Given this list of marker genes PDGFRA, here is a description of the gene set: species: Homo sapiens Reactome Pathway: PDGFR mutants bind TKIs Aberrant signaling by activated forms of PDGFR can be inhibited by tyrosine kinase inhibitors (TKIs). PDGF receptors are class III receptor tyrosine kinase receptors, also known as dual-switch. Dual-switch receptors are activated through a series of phosphorylation and conformational changes that move the receptor from the inactive form to the fully activated form. Type II TKIs bind to the inactive form of the receptor at a site adjacent to the ATP-binding cleft, while type I TKIs bind to the active form.<br><br>Primary mutations in PDGRFA occur in the activation loop, with a minor fraction found in the juxtamembrane domain. Juxtamembrane domain mutations affect an autoinhibitory loop, shifting the equilibrium of the receptor towards the activated state; despite this, however, juxtamembrane domain mutants remain predominantly in the inactive state and as such are susceptible to inhibition by type II TKIs. Activation loop mutations more strongly favor the active conformation of the receptor and are susceptible to inhibition by both type II and type I TKI. The most prevalent PDGFRA mutation, D842V, promotes the active conformation strongly enough to be resistant to type II TKIs. part of: Signaling by PDGFR in disease